The following is a description of a gene set: Reactome Pathway: Defective FMO3 causes TMAU part of: Metabolic disorders of biological oxidation enzymes species: Homo sapiens Trimethylamine (TMA) is present in the diet (in fish) but primarily formed in vivo from the breakdown of choline. It is N-oxidised by FMO3 in the liver, the major isoform active towards TMA. Trimethylaminuria (TMAU; MIM:602079, fish-odour syndrome) is a human genetic disorder characterised by an impaired ability to convert the malodourous TMA to its odourless N-oxide. Patients emit a foul odour, which resembles that of rotting fish and can be a psychologically disabling condition., and this is the list of marker genes: FMO3